Given this list of marker genes ADGRB3, P3R3URF-PIK3R3, HPS1, TTC14, GABRG1, SKIL, CFAP61, BNIP2, BAG5, SUGT1, TM2D3, ETNK1, FGF12 (fibroblast growth factor 12), SERTAD2, SLC7A2, ETF1, SLC30A7, AAK1, VGLL3, TET3, MOB1B, PTPRZ1, PSIP1, CD47, FBXL17, PALM2AKAP2, GTF2A1, ADNP, TIAL1, ATL3, PIGN, DNAJB5, ZNF24, ARAP2, ABI1, DLEU7, WDR44, ACSL3, NPM3, YES1, RORA, PIK3R1, SH3TC2, RNF19A, ZNF20, USP13, HECTD2, PPP4R2, SKAP2, OTUD7B, SLC2A13, ACVR1C, SLC4A10, ADGRE2, GABRB2, NFYA, KLHL11, ROR1, GNAI3, KDM5B, ADAM17, CNOT7, RGS13, PLD5, USP49, NRIP1, KLHL5, COMMD9, MDFIC, CECR2, NTF3, ZEB1, ANKRD28, SIAH2, MAF, CDYL, ZNF706, ORC4, PRKAA2, ZDBF2, ZNF704, ZNF382, NUP62CL, ARK2N, INPP5F, NCOR1, RBBP4, FAM169A, NKX2-1, IQGAP2, DYRK2, SMIM13, TVP23B, RBM47, IKZF2, SMIM8, B4GALT4, GTF2I, TMEM50A, GRIA2, ARID1A, ZC3H12C, DICER1, ATRNL1, SYNCRIP, SLC17A2, ZNF280D, MYEF2, DAZ3, MIB1, MYBL1, RASEF, PPFIA1, DUSP15, TJP1, DYNLT3, GNG2, HDX, ERBIN, CNST, KANSL1L, RANBP3L, ANKIB1, SON, PUS7, ANKS1A, ICAM5, STARD4, USP24, PCDH11X, SELENOI, MAPKAPK2, PPAT, GCLC, CBLL1, FSBP, CREBRF, KLHL24, VEZF1, G2E3, VKORC1L1, SCYL2, RAF1 (NCBI Gene Id 5894), AFF1, MYC, UBN2, ZNF468, UBR5, PRMT3, EYA3 (NCBI Gene Id 2140), KLHL28, MME, DAZ2, CRY1, RYK, TMEM41B, HMGXB4, SLCO5A1, TNPO1, ZNF326, IGF2BP3, JAK2, SSH2, DYNC1LI2, RPS6KA3, EMC1 (NCBI Gene Id 23065), PAN3, GTF3C4, PUM2, ZSWIM6, SOST, MARK1, RAD54B, RRP15, C12orf75, PTPN5, MANEA, CARF, PSMA1, EXOSC9, XRN2, PDE4D, NR2C2, KLHL15 (kelch like family member 15), EGR3, SOX6, DCAF17, PRKAR1A, GFPT1, CLGN (NCBI Gene Id 1047), EIF5A2, ARL6IP6, FGD6, MCTP1, PCGF5, KDELR1, SERPINB1, LIG4, PTH2R (parathyroid hormone 2 receptor), SCN9A, NAA15, PRPF6, TMEFF2, HOXA3, TET2, GPR63, NANOGNB, YWHAZ, PHF14, CCNT1, GJA3, SRFBP1, INPP4A, PLEKHM3, GLCE, CREB1, PARP15, EIF4B, EPC1, RPRD1A, CAMSAP2, ANO5, MED1, ABCD4, NUFIP2, AKAP5, DAZ4, MTCL3, LEMD3, ZNF365, DIS3L2, FOS, UBE2H, SECISBP2L, TRIP12, FRMD5, ZFHX3, SKI, PRKCA, DDX55, PRRC1, PDS5B, FBXO43, CXCR4, ZNF322, SPOCK3, OAF, SPTSSA, TNRC6B, FARP1, ACVR1, TBL1X, AGBL3, DPP8, DCDC2, KCNQ5, SETBP1, DPP10, CDKN1B, PYGO1, CCNYL1, HIPK2, PAG1, GAS1, MBNL3, SLC25A44, AGR3, VPS13C, QTRT2, AVL9 (NCBI Gene Id 23080), SPIRE1, LIN28B, FER, PRKCI (protein kinase C iota), ATOSA, C21orf91, HIF1A, UHMK1, ARGLU1, WNK3 (WNK lysine deficient protein kinase 3), RAB23, MOSMO, AP1AR, YIPF6, LIN7C, SASS6, MICU3, EVI5, USP38, CREM, PM20D2, PCDHB15, CADM2, ETS1, VASP, SCAI, PPP2R5E, KPNA4 (karyopherin subunit alpha 4), TRIM36, ST6GAL1, SOCS6, ZNF148, GABRA4, ANKRD13C, SOX2, ANKH, ACVR2B, YTHDF3, TAF5, DHX32, HNRNPR, HDAC4, FYN, XPR1, RAC1, MED13L, RBBP8, CCDC73, TOX, TBP, LIN7A, SOCS5, MAPK8, NLGN1, CYP8B1, FLRT2, SINHCAF, IGFBP3, C5orf24, DIP2B, VCPIP1, GABRB3, DIMT1, ZNF561, HERPUD2, TSC22D2, MARCHF4, SLC23A2, GPATCH2, RIMS1, SMARCA5, SLC25A16, DCLK1, TBC1D22B, ANLN, PROSER1, ZBTB44, ZNF682, LLGL2, GSPT1, DCBLD2, SGMS1, MED13, SP4, ATF7IP, COA5, EREG, FAM177A1, DNMT3B, BEND4, TRPC1, IRAK2, TGFBR1, ZMPSTE24, SMC5, LSM8, STAG2, APPBP2 (amyloid beta precursor protein binding protein 2), CSNK1A1, PEX5L, CAMTA1, TMEM135, ALCAM, MFAP2, DDX4, CRISP1, FBXO11, RNGTT, CYP2U1, RIT2, ARID4A, OAS3, RBMS3, HYCC2, ARFGEF3, RBPJ (recombination signal binding protein for immunoglobulin kappa J region), RNF217, GPR155, ACBD5, CCL3L3, ERO1B, RPS3, LZIC, CDK17, PSD3, PLEKHB2, LPP, PTBP3, DBI, ATP2B4, AZIN1, PDS5A, MCL1, WDR37, MCF2L2, SMC2, PARD3, DCP1A, PDE1A, MED6, TOX3, HOXA9, ANO4, PAK2, FHDC1, MEF2C, ASAP2, ZNF469 (zinc finger protein 469), FYTTD1, CPSF6, IDE, PTBP2, G3BP1, FGFR3, TMPRSS11F, TMPO, MAP3K2, SPICE1, OXGR1, SOAT1, SOX21, PTPRK, CKAP2, ARHGAP32, ELMOD2, MPHOSPH9, NAPG, ABHD13, UBAC2, ZNF609, TFDP1, XRN1, ABCA5, RAB3C, MBNL1, ARL6IP5, MAP4, ZNF367, AEBP2, USP42, ZFAND5, TUT4, ST6GALNAC5, NAB1, MINDY2 (NCBI Gene Id 54629, MINDY lysine 48 deubiquitinase 2), AMFR, B3GAT1, ZYG11B, SUZ12, KDM7A, ERGIC2, USP37, WASF1, DAG1, IGFBPL1, CCZ1, MOSPD1, ZNF750, GAB1, SUFU, TM7SF3, RSBN1 (NCBI Gene Id 54665), HDAC9, DNMT1, STRA6, BLOC1S2, SAR1B, STK24, AMER2, UBXN4, MAFG, DYRK1A, HYCC1, APPL1, AGO2, GNL3L, ZBED4, PDE10A, CPNE8, UBE2D1, LCOR, MAPK6, FAM83B, FZD1, JADE3 (jade family PHD finger 3), CCND1, USP46, DCUN1D4, ARHGAP29, YIPF4, GTF2B, BPNT2, SH3GLB1 (SH3 domain containing GRB2 like, endophilin B1), GPC6, UFM1, RPL34, SREK1IP1, COL1A1, STRBP, RANBP1, DAZ1, ELOVL4, NABP1, ITPRIPL2, C2orf49, NIN, B4GALT6, GKAP1, DTNA, DUS4L, SHPRH, ZNF681, GPC4, FKBP5, TCF7L2, MTSS1, TMEM170A, FBXW2, CLDN11, LPCAT2, KNTC1, CYP4V2, DENND1B, SLC38A1, HNRNPF, CCDC71L, NOL4, ZNF562, ATP2A2, GPD2, TLDC2, RPS6KA6, TMED2, PLAC8L1, CTNND1, SNW1, SLC35D1, UTRN, LHX9, PDE7A, TTYH2, KCTD12, SEH1L, PPP1CC, BCLAF3, KIAA1210, TAOK1, MCTS1, GSE1, PURG, TMCO1, TFPI2, DMRTA1 (NCBI Gene Id 64125), REDIC1, CELF2, SSU72, IRX2, MCU, ARL5A, FAT1, PCDH20 (NCBI Gene Id 80245), MARCHF5, KCNJ2, MAP2K4, SAMD8, MAP2, SOS2, PPP4R3A, PPP3CA, NOVA1 (NOVA alternative splicing regulator 1), HBEGF, MBTD1, RBM12B, GORAB, USP10, CDK6, SNRPD1, SLC25A36, TP53INP1, IPMK, ARL14EP, TVP23C (NCBI Gene Id 93602), ATXN1, NET1, AKR1D1, OSBPL8, TGS1, HOXA5, QKI, AAGAB, FAM171B (NCBI Gene Id 165215), PNISR, ZNF740, ZNF678, NPM1, FAM241A, SORBS1, GABBR2, RSPRY1, PIK3CA, FZD3, PHIP, FOXP2, ICE2, NEXMIF, MED30, CNEP1R1, KRAS, COL4A1, PPP6C, ELAVL1, TIGD3, SYT4, PRSS35, RBM24, SCG2 (NCBI Gene Id 7857), UGGT1, EFEMP1, B3GALT2, CCNA2, RECQL, FMNL2, CCZ1B, N4BP2L2, INO80D, SLC9A1, BACE1, THSD7B, PPM1K, REV1, CNOT6L, SLC16A7, ZDHHC21, CPEB4, CNTNAP2, ZFR (zinc finger RNA binding protein), MAML3, SLC10A4, SLC12A2, GNB4, PLAGL2, PLPPR4, SMURF2, VAPA, RP2, VPS4B, DTD1, PPP2R2B, ROBO1, SLC7A11, MCC, ZBTB41, L2HGDH, DPY30 (NCBI Gene Id 84661), USP25, ZNF264, RBM27, SHISAL1, NEK7, UBXN2B, KCMF1, NAMPT, TXNRD3, FBXL20, BRD10, USP15, AHSA2P, ZMYM3, YTHDF1, DCK, SERINC3, PTPDC1, PKD2, MMGT1, DACT1, PRMT1, YBX1, DLG1, SBSPON, PHF20L1, MEX3B, CPEB3, EPG5, ZNF236, TRHDE, RC3H1, RNF180, TGDS, IFT56, PRKCB, PFKFB2, ZEB2, KMT2D, FAM220A, CD38, ESRP1, DDA1, PGR, FRS2, SYT1, STOX2, PIK3R3, PAPOLA, MMD, CPEB1, FERMT2, HMGN1, IGSF5, MMADHC, TBL1XR1, FLI1, MED12, USP53, SFPQ, AFAP1, NAA50, TRIM33, SLC19A2, TOMM70, BDP1, PHACTR2, ERBB2, NHLH2, PHC3, SLC4A7, BCOR, BTBD7, MARCKSL1, RIMKLB, ZDHHC17, LRATD2 (LRAT domain containing 2), GGCX, DNAJC19, NSD2, COQ10A (NCBI Gene Id 93058), ACTR3B, ZBTB2, SNX16, CTDSPL2, STRN3, SIDT2, SUB1, SLC18B1, KIAA0408, FOXN2, GABPB1, BCAR1, DCAF12L1, GTDC1, MSTN, RNF139, B3GALNT2, ADH7, MRPS11, BPTF, ING3, APH1A, AOX1, TMEM64, TC2N, UBE2W, CIP2A, PTPRD, ABLIM2, AGPS, ZNF652, MPZL1, DPY19L1, ASPH, ATF1, NAP1L1, NOTCH2, TLNRD1, FSTL1 (NCBI Gene Id 65385), PELI1, ABHD2, here is a description of the gene set: from publication Chen Y, Wang X (PMID 31504780) studied in species Homo sapiens Human Gene Set: MIR548AE_3P_MIR548AQ_3P Genes predicted to be targets of miRBase v22 microRNA hsa-miR-548ae-3p, hsa-miR-548aq-3p in miRDB v6.0 with MirTarget v4 prediction scores > 80 (high confidence targets).